Given this list of marker genes AK4, UMPS, AK5, DHODH, GUK1, CAD, AK2, AK9, CMPK1, AK3, AK1, here is a description of the gene set: species: Homo sapiens Human Gene Set: GOBP_RIBONUCLEOSIDE_DIPHOSPHATE_BIOSYNTHETIC_PROCESS The chemical reactions and pathways resulting in the formation of a ribonucleoside diphosphate, a compound consisting of a nucleobase linked to a ribose sugar esterified with diphosphate on the sugar.